The following is a description of a gene set: Cytokines mediate cell-cell communication in the immune system and represent important therapeutic targets. A myriad of studies have highlighted their central role in immune function, yet we lack a global view of the cellular responses of each immune cell type to each cytokine. To address this gap, the authors created the Immune Dictionary, a compendium of single-cell transcriptomic profiles of more than 17 immune cell types in response to each of 86 cytokines (>1,400 cytokine-cell type combinations) in mouse lymph nodes in vivo. A cytokine-centric view of the dictionary revealed that most cytokines induce highly cell-type-specific responses. For example, the inflammatory cytokine interleukin-1β induces distinct gene programmes in almost every cell type. A cell-type-centric view of the dictionary identified more than 66 cytokine-driven cellular polarization states across immune cell types, including previously uncharacterized states such as an interleukin-18-induced polyfunctional natural killer cell state. Genes negatively differentially expressed in cell type: Treg upon treatment with cytokine: IL-36α in mouse lymph nodes in vivo. from publication Cui A, Huang T, Li S, Ma A, Pérez JL, Sander C, Keskin DB, Wu CJ, Fraenkel E, Hacohen N (PMID 38057668) studied in species Mus musculus Mouse Gene Set: CUI_TREG_IL36A_RESPONSE_DN, and this is the list of marker genes: Pold4, Pdcd4, Smpdl3a, Ucp2, Emp3, S100a10, Mbnl1, Ypel3, Mxd4, Limd2, Cd3g, Laptm5, Foxp1, Ccdc88c, Crip1, Tesc, Ahnak, Arhgdib, Cd52, Il7r, Fxyd5, Ptprcap, Ltb, Rac2, Capn3, Lbh, Arhgef1 (Rho guanine nucleotide exchange factor 1), Evl, Rgs10, Eif3e, Macf1, Nrp1, Lsp1